The following is a description of a gene set: Mouse Gene Set: MIR_291B_3P studied in species Mus musculus from publication Chen Y, Wang X (PMID 31504780) Genes predicted to be targets of miRBase v22 microRNA mmu_miR_291b_3p in miRDB v6.0 with MirTarget v4 prediction scores > 80 (high confidence targets)., and this is the list of marker genes: Map3k12, Ndel1, Spred1, Prkaa1, Map3k9, Garem1, Mylk, Psd, Tesk2, Zfp367, Bmpr2 (bone morphogenetic protein receptor type 2), Prdm8, Btbd10, Rasl11b, Sorl1 (NCBI Gene Id 72910), Arap2, Jmy, Has3, Smoc1, Frmd6, Mex3d, Smad5, Hbp1, Ubxn8, Elk3, Cast, Polq, Sobp, Ago1, Tnks1bp1, Hif1an, Cmpk1, Fgf9, Kmt2a, Myrf, Fzd6, Crppa, Acer2, Stx6, Abhd3, Suv39h1, Rad51b, Sash1, Mtbp, Tgfbr2, Asxl2, Gab1, Kcnd2, Apcdd1, Zbtb4, Npas2, Itpr1, Erbb4, Zhx2, Zfp11, Il25, Rufy2, Laptm4a, Aak1, Zfp661, Mfsd6, Tmcc3, Cfl2, Golga1, Zfp286, Map7, Panx2, Lamp2, Emx2, Dennd10, Miga2, M6pr, Tnf, Smoc2, Klhl20, Nfib, Kcnn2, Arhgap6, Map3k8, Rb1, Dpysl2, Afg1l, Tspan9, Lrig1, Nabp1, Mfap3l, Lmx1a, Pde12, Pdik1l, Bnip2 (BCL2/adenovirus E1B interacting protein 2), Rasd1, Actl6a, Snrk, Itgb4, Pgm2l1, Ptgfrn, Map1b, Limk1, Rorb, Sorbs2, Nfia, Pdgfra, Larp4, Znrf3, Mtmr4, Blcap, Oxsr1, Kdm2a, Stk17b, Nrp2, E2f7, Synpo2, Tnfrsf21, Cdk2, Ppp2r1b, Pdzd7, Bnc2, Nat3 (NCBI Gene Id 17962), Casd1 (NCBI Gene Id 213819), Arhgap12, Vwde, Usp3 (NCBI Gene Id 235441), Kmt2b (NCBI Gene Id 75410), Pitpna, Mapk8, Zfp704, Btf3l4, Nhlh2, Adipor2, Kcna1, Wdfy3, Slc40a1, Neurog3, Heg1, Myocd, Lclat1, Mosmo (modulator of smoothened), Ankib1, Ppp1r15b, Atxn1l, Bbx, Ube3a, Csnk1g1, Fcho2, Tspyl2, Sema7a, Slc24a2 (solute carrier family 24 (sodium/potassium/calcium exchanger), member 2), B3galt2, E2f1, Spty2d1, Sumf1, Usp32, Plcb1, Cep120, Mier1, Tapt1, Arhgap1, Pthlh (NCBI Gene Id 19227), Man1c1, Psd3, Tbc1d12, Arhgef11 (Rho guanine nucleotide exchange factor 11), Naa30, Dcbld2, Becn1 (NCBI Gene Id 56208), Mbnl1, Pxk (NCBI Gene Id 52518), Jak1, Tanc2, Tmem170b, Crybg3, Irf2bp2, Mapk1, Prdm16, Ccdc88a, Tox3, Slain1, Sos1, Reps2, Phtf2, Zfp91, Nipa1, Zfand4, Aldh1b1, Rab5c, Cdadc1, Ankrd10, Fstl5 (follistatin-like 5), Acsl4, Tfap4, Gid4, Tsn, Atg16l1, Elk4, Prr14l, Gcc2, Sh3pxd2a, Hs3st5, Sfmbt1, Rfx5, Cul3, Jakmip1, Map3k2, Cpeb1, Tbcel, Kif5a, Wasf1, Yaf2, Arid4b, Arhgap29, Fbxl5, Mup3, Chmp4c, Pkd2, Ezh1, Mup20, 6430548M08Rik, Chd9, Snx5, Ikzf2, Rnf2, Stxbp5l, Zbtb41, Frrs1l, Btbd7, Arid4a, Caprin2, Topors, Pafah1b1, R3hdm1, Gpr137c, Cnot6l, Erbin, Wee1, Rnf216, Hivep2, Fastk, Dnajb9, Ankrd44, Mybl1, Bmt2, Atp2c1, Dcaf8, Insyn2b (inhibitory synaptic factor family member 2B), Mbnl3, Hey2, Cldn8, Btg1, Rictor, Rasgrf2, Cnot6, Zfhx4, Nckap5, Cnot7, Tbc1d15, Skida1, Rtn1, Hs3st3b1, Slc25a36, Atl3, Kbtbd2, Gabrr1, Spopl, Ddhd2, St6galnac3, Kcnk10, Znfx1, Hoxa3, Arx, Cyyr1, Grb10, Pcsk5, Ppp1r9a, E2f2, Zbtb18, Cds1, Plekha3, Trp63, Fibin, Tafa1